The following is a description of a gene set: CHRNA7-E2F signaling pathway. Pathway ID: N01336. Pathway type: Reference. Pathway class: nt06230 Cell cycle. Pathway Definition from KEGG: ACh -> CHRNA7 -> ARRB1 -> SRC -> RAF1 -> RB1 // E2F1 Human Gene Set: KEGG_MEDICUS_REFERENCE_CHRNA7_E2F_SIGNALING_PATHWAY species: Homo sapiens, and this is the list of marker genes: RB1, SRC, ARRB1, CHRNA7, RAF1, E2F1